Given this list of marker genes PGR, SERPINB3 (NCBI Gene Id 96249), FGF2, CGAS, CD34, PDGFB, TNFSF11, here is a description of the gene set: studied in species Homo sapiens The transfer of information from one cell to another, where the signal travels from the signal-producing cell to the receiving cell by passive diffusion or bulk flow in intercellular fluid. The signaling cell and the receiving cell are usually in the vicinity of each other. Human Gene Set: GOBP_PARACRINE_SIGNALING